Given this list of marker genes TP53INP1, LIMS1, LAMP1, ADAM23, RPL22, DYRK1A, ACAP3, BSN, ZNF799, MORC3 (NCBI Gene Id 23515), TMEM168, SCLT1, CMIP, KMT2A, FOXD1, ACTN4, PCLO, GJB4, MYCBP, NEUROD6, USP44, FBXO33, VWA5B2, ARID1A, SBNO2, TNRC6B, CACNB4, RYR2, ROR1, ATG5, NFATC3, DUSP3, PTBP1, SLC4A4, KLF5, MDN1, PTPN3, DMXL2, FAM168B, ADGRA2, NFIB, FOXR2, ADAMTS8, KMT2B, IRX2, HPS6, NRARP, RPS6KA5, NPTN, WDR26, MFAP3L, DDIT4 (NCBI Gene Id 54541), SNAI1, GFPT2, PLEKHA3, RYR3, C5orf24, QKI, LDLR, C9orf40, UBE2K, SERTAD2, DNM3, UNC5A, CELF6, CBLIF (cobalamin binding intrinsic factor), ITSN2, ASB7, GPR158, TAGLN3, GLCE, SETD7, TNFSF8, GAB1, SPTY2D1, SLC1A6, NFE2L2, C21orf91, C8orf44-SGK3 (NCBI Gene Id 100533105), UBE2W, ZFYVE9, FAM168A, RASA1, OTUD4, BTBD7, SPATA18, OTUD7B, TTYH3, EPHA4, DCUN1D1, GRIP2, TNRC6C, TXNDC11, OPRM1, MTF1, RUNX2, PTCH1, TCERG1L, MAGI1, KCNRG, ITPR1, GRIP1, RPS6KB1, KCNQ4, APBB2, MOSMO, ING2, COL19A1, FZD3, PPM1D, CD109, DPY19L1, CCDC50, HERC3, ISCA2, WWP1, IPO5, CFL2, MAP4K5, MITF, MBTD1, TAF1, ANKRD40, MTMR12, SPTSSB, LAMC1, RB1CC1, STEAP2, ADO, CAPN15, ZNF704, GNAI3 (G protein subunit alpha i3), SGCZ, AZIN1, FRMD5, PAXBP1, ERO1B (NCBI Gene Id 56605), BCL2, EBF2, FHIP1A, ABHD13, MEF2C, OTX2, DENND1B, ROCK1, SORL1, RICTOR, SLCO5A1, NUDT4, FBXO8, LAMP5, GAN (gigaxonin), TTC28, RNGTT, KLF7, KATNIP, KCNA6, MIER3, SATB1, DACH1, CACNA1B, KCNIP4, GNPDA2, ZDHHC1, ZNF443, ATAD2B, SPHK2, SPTBN4, SLC14A1, SUN2, SCN3A, AUTS2, SOCS2, RCOR1, SOCS5, EXPH5, ZNFX1, FBXO4, JADE1, BEND4, NFIA, LRP12, NEUROD4, KDSR, OXR1, CBFB, SMARCD2, PRDM2, AGO3, PURA, RAI14, IDO1, ANKRD29, LATS1, CKAP4, SH3BP4, GALNT7, JARID2, DLG2, ME1, HEY2, USP31, CLCN5, CAMKK2, OSBPL6, KBTBD8 (kelch repeat and BTB domain containing 8), SESTD1, TES, USP28, PAX4, CUX1, SEMA4G, BACH2, CHN2, PMP2, UBN2, FERMT2, PLCB1, ZNF441, TTC6, PPP1R12A, MON2, KCNA1, APC, HIPK3, PIP4P2, XYLT1, DCLRE1B, ZNF385D, ADAM19, GRB2, ZCCHC14, IFFO2, C2CD2, ANGPT1, SYT10, YIPF2, SEPTIN8, NAV2, CAP1, AGO1, CADM2, TRUB1, FURIN, TBC1D19, ANK1, PIK3R1, EEIG1, INO80D, ATOSA, PIGA (phosphatidylinositol glycan anchor biosynthesis class A), CITED2, KCND1, PCDH7, ZNRF2, NFATC2, CNN3, DGKH, RASL12, UTY (NCBI Gene Id 7404), SGCD, UNC5C, RTN4, FOXO3, KCTD1, PDP2, SIGMAR1, SLC16A7, WIPF1, CIB2, KIF20A, KDM6A, POU4F1, GATM, BPTF, PAIP1, KCNH7, PHF13, APP, VASH2, PCTP, RABGAP1, TMEM38B, WIPF2 (WAS/WASL interacting protein family member 2), EPDR1, MOV10, HTR1F, ZDHHC6, GRIK4, ZBTB2, SCML2, UTRN, UXS1, GAREM1, KCTD6, ARMH4, ZNF592, DMD, RBAK, TPCN1, RALGPS2, DCLK1, GGCX, PDS5A (NCBI Gene Id 23244), INHBB, ROBO2, JAG1, FBXL3, DESI2, ZBTB43, IBSP, HLCS, GABPA, SLC9A9, RAB11FIP2, FEM1C, NFIC, UBFD1, SGK3, GMCL1, ATXN7, ZNF521, SGMS2, TESK2, ZCCHC2, CCDC32, RASSF4, AMPH, KCTD5, here is a description of the gene set: from publication Chen Y, Wang X (PMID 31504780) species: Homo sapiens Genes predicted to be targets of miRBase v22 microRNA hsa-miR-153-3p in miRDB v6.0 with MirTarget v4 prediction scores > 80 (high confidence targets). Human Gene Set: MIR153_3P